The following is a description of a gene set: Mouse Gene Set: GOBP_INTRACELLULAR_MRNA_LOCALIZATION species: Mus musculus Any process in which mRNA is transported to, or maintained in, a specific location within the cell., and this is the list of marker genes: Zfp36l1, Hnrnpab, A1cf, Htt, Fubp3, Ckap5, Casc3, Qki, Stau1, Zfp385a, Zfp36, Dhx36, Pum2, Stau2, Caprin1, Kif5c